The following is a description of a gene set: Human Gene Set: TRAVAGLINI_LUNG_NATURAL_KILLER_CELL from publication Travaglini KJ, Nabhan AN, Penland L, Sinha R, Gillich A, Sit RV, Chang S, Conley SD, Mori Y, Seita J, Berry GJ, Shrager JB, Metzger RJ, Kuo CS, Neff N, Weissman IL, Quake SR, Krasnow MA (PMID 33208946) species: Homo sapiens, and this is the list of marker genes: PYHIN1, NCALD, IGFBP7 (NCBI Gene Id 3490), ISG20, IFITM1, AKNA, KLRC1, CD300A (CD300a molecule), SAMD3, PLAAT4, ETS1, PPP2R5C, TXK, SELPLG, MYOM2, UBB, HLA-C, CLIC3, MAPRE2, SLA2, DTHD1, RAP1B, SYTL3, FKBP11, FGFBP2, ITGAL, PTGDR, CX3CR1, CHST12, S1PR5, MATK, RUNX3, ARL4C, BPGM, CD247, PTPN4, SPON2, IL2RB, GZMB, ABHD17A, KLRC3, APOBEC3G, AOAH, CCDC107, DHRS7 (NCBI Gene Id 51635), CALM1, HSH2D (hematopoietic SH2 domain containing), ARPC2 (actin related protein 2/3 complex subunit 2), GZMH, HDDC2, C12orf75, PIP4K2A, DDIT4, CARINH, PRSS23, ZAP70, CNOT6L, CEP78, KLRC2, RHOC, CD244, SH2D2A, RASSF1, GNLY, FCRL6, MAPK1 (mitogen-activated protein kinase 1), GZMM, OSBPL5 (oxysterol binding protein like 5), ABI3, BIN2 (bridging integrator 2), GZMA, TBX21, TFDP2, YPEL1, PRKCH, EBP, TIGIT, CCL5, CD7, NMUR1, DHRS3, KLRB1, NHERF1, NKG7, SIGLEC7, SPN, FCGR3A, F2R, USP28 (NCBI Gene Id 57646), HAVCR2, TPST2, ANKRD20A11P, GPR65, GSAP, PLAC8, ADGRG1, SYNE1, PRF1, B2M, AKR1C3, GFOD1, PFN1, LITAF, AREG, CMC1, CD160, MYBL1, APMAP, ID2, CST7, GNG2, EFHD2, DUSP2, ITGB2 (integrin subunit beta 2), CHST2, PRDM1, TTC38, CTSW, SH2D1B, RAC2, GIMAP7, TMIGD2, CLEC2B, GYPC, SLAMF7, OSTF1, KLRD1 (killer cell lectin like receptor D1), IL2RG, HOPX, KLRF1, ZBTB16, C1orf21